The following is a description of a gene set: from publication Chen Y, Wang X (PMID 31504780) Mouse Gene Set: MIR_6926_3P species: Mus musculus Genes predicted to be targets of miRBase v22 microRNA mmu_miR_6926_3p in miRDB v6.0 with MirTarget v4 prediction scores > 80 (high confidence targets)., and this is the list of marker genes: Tnfrsf13c, Aak1, Trappc3l, Cypt1, Rnf152, Tmem265, Mccc1, Galnt7, Cyb561d1, Sp100, Aco2, Rab12, Ppp1r3c, Cyfip2, Lrrc4c, Ets1, Adamts5, Gfra1, Fam76b, Rab33b, Saal1 (NCBI Gene Id 78935), Rilpl2 (Rab interacting lysosomal protein-like 2), Timp1, Uvssa, Kcnma1, Cyp2c65, Aqp4, Cypt3, Chrm3, Morf4l2, Cypt2, Scml2, Ttpa, Ccdc134, Kirrel2, Zbtb5, Mug2, Tdo2, Zc3h11a, Klf4, Pip4k2a, Afmid, Ccnl1, Pcsk5, Ndel1, Clcn5, Tnc (NCBI Gene Id 21923), Cypt12, Mug1, Plekha3, Eps15l1, Stk26 (serine/threonine kinase 26), Blmh (NCBI Gene Id 23826), Rtn1, Rnf185, Calcb, Sestd1, Tmem81, Sst, Atp2b1, Cypt4, Coq3, Minar1, Ift57, Fbxo41 (F-box protein 41), Gja5, Lpar3, Slitrk1, Epha5, Tmem200c, Ifnlr1, Ncald, Col5a2, Sned1, Col19a1